The following is a description of a gene set: studied in species Homo sapiens A subcompartment of the endoplasmic reticulum in which proteins with improper or incorrect folding accumulate. Enzymes in this compartment direct proteins with major folding problems to translocation to the cytosol and degradation, and proteins with minor folding problems to the ER, to interact with chaperon proteins. Human Gene Set: GOCC_ENDOPLASMIC_RETICULUM_QUALITY_CONTROL_COMPARTMENT, and this is the list of marker genes: RNF103, EDEM2, MAN1B1, RNF139, DERL1, UGGT1, CALR, SYVN1 (synoviolin 1), RNF5, EDEM3, ERN2, EDEM1, SEC61B, ASGR2, FBXO6, MARCHF6, UGGT2, HERPUD1, CANX, RHBDD1, TRIM13, RNF185, AMFR, ERLEC1